Given this list of marker genes CEP170B, MSANTD4, CASK, PPP3R1, TAFA1, CDK17, DTX3, CCND2, KRAS, KIAA1217, PARD6B, ZMYND11, ARHGAP5, UEVLD, CRK, NAP1L5, ACTL6A (NCBI Gene Id 9178), C18orf32, SMARCA1, KCTD9, PRP4K, HNRNPH2, EPB41L5, YWHAZ, VAMP4, PIGF, TPD52, GABRA1, FBXO33, PLCG1, NR2F2, CPEB4, NR4A3, NCKIPSD, SOX21, SET, DR1, CALD1 (NCBI Gene Id 800), TP53INP1, SERF2, SLC16A1, FAR1, EPHA7, KCNN2, RSF1, ERBIN, FRAS1, SNX31, TMEM47, CCSER2, DPYSL3, SLITRK6, CTNND2, NEGR1, SOX3, DCP2, ZNF385B, HMGB2, ZFP36L1, MAP3K7, LRP12, TCEA1, CFL2, NR3C1, RAB14, SRCIN1, ATMIN, CNTN4, SORCS3, SLC25A37, KLC1, ATP11A, RBBP5, HNRNPA2B1, UBE2K, GK5, ITGB1, BMAL1, MAP7, HOXB5, RARG, TPM1, TIMP3 (TIMP metallopeptidase inhibitor 3), HS6ST2, HOXB13, DNAJC16, SAR1B, HIPK1, MMP16, ZHX1, ANKRD10, SOCS4, ATXN1, ZFPM2, CELF2, E2F3, PITPNM2, KCNJ3, PPP1R8, MEF2C, SRSF2, ZNF281, SREK1IP1, NDEL1, LMBRD1, ETF1, KAT2B, KRIT1, GABRB3, WAC, NFKBIZ, MITF, ENAH, FAM133B, CEP41, VPS13A, KPNB1, AKT3, UBE2D3, PRKCE, CKAP5, RELT, GOLGA4, PHF2, ZMYM4, CPEB2, AGFG1, MXD1, PCDH18, HTR2C, SKAP2, STK4, TRIM33, ZBTB18, MIB1, TNRC6B, GPHN, S1PR1, SFMBT1, GNAI2, QKI, LRRC4, RAP2C, SOX4, MTMR12 (NCBI Gene Id 54545), POU4F1, MAGI1, SORBS2, SLITRK2 (SLIT and NTRK like family member 2), SKP1, NLK, STX16, CYGB, MECP2, UBE2W, NT5DC3, CKAP2L, BCL11B, ZNF362, NSMCE4A, PHF20L1, ZIC2, CPEB3, JADE3, TEAD1, VCPIP1, CAMK2G, STRN3, LRATD2, SORCS1, STC1, CREBZF, PALM2AKAP2, ZNF664, RIMKLA, CIT, SENP1, GSPT2, C1orf21, CRISPLD1, YAF2, DDX3X, ELAVL2, TMEM30A, TRAPPC11, SLITRK3, PHF6, TLL2, CCN1, JAZF1, DNAJC6, E2F7, ZFHX4, SMARCA2, GSPT1, SOX2, GABBR2, THRB, CPSF6, CYTH3, LRP4 (LDL receptor related protein 4), INSM1, DCX, FXR1, PDS5B, SP5 (Sp5 transcription factor), LRRTM1, STAT1, FBXO22, DVL2, POU3F2, PALS1, RBM39 (RNA binding motif protein 39), GPM6A (NCBI Gene Id 2823), PDK1, THBD, PSMD7, PCMTD1, PI15, OSBPL8, BACH2, CREB5, ESCO1, FYCO1, TFAP2B, PCDH19, EIF4ENIF1, SLC9A9, TARDBP, KMT5A, KLHL3, AFF3, NKRF, ELOVL6, NDST1, here is a description of the gene set: Genes having at least one occurence of the motif TAGCTTT in their 3' untranslated region. The motif represents putative target (that is, seed match) of human mature miRNA hsa-miR-9* (v7.1 miRBase). studied in species Homo sapiens Human Gene Set: TAGCTTT_MIR9